Given this list of marker genes E2f7, Ccne1, Cdkn1b, Cdkn1a, Ccne2, Ccna1, here is a description of the gene set: part of: TP53 Regulates Transcription of Cell Cycle Genes electronically inferred by orthology from the curated human pathway Reactome Pathway: TP53 Regulates Transcription of Genes Involved in G1 Cell Cycle Arrest studied in species Mus musculus This event has been computationally inferred from an event that has been demonstrated in another species.<p>The inference is based on the homology mapping from PANTHER. Briefly, reactions for which all involved PhysicalEntities (in input, output and catalyst) have a mapped orthologue/paralogue (for complexes at least 75% of components must have a mapping) are inferred to the other species.